Given this list of marker genes GRPEL1, GRPEL2, PAM16, DNAJC15, DNAJC19, here is a description of the gene set: Human Gene Set: GOCC_PAM_COMPLEX_TIM23_ASSOCIATED_IMPORT_MOTOR Protein complex located on the matrix side of the mitochondrial inner membrane and associated with the TIM23 mitochondrial import inner membrane translocase complex ; ATPase motor activity to drive import of proteins into the mitochondrial matrix. species: Homo sapiens